Given this list of marker genes SF3B4, WNT7A, PORCN, SEM1, TAF6, RIPK4, BRD4, TP63, CYP26B1, APC, NIPBL, DLX6, HOXD13, H4C3 (H4 clustered histone 3), MBTPS2, SMOC1, DLL4, BTRC, DLX5, FBXW4, SMC3, EPS15L1, SMC1A (structural maintenance of chromosomes 1A), WNT10B (Wnt family member 10B), RAD21, DONSON, HDAC8, LRP4, RECQL4, ERI1, GLI3, here is a description of the gene set: species: Homo sapiens Human Gene Set: HP_OLIGODACTYLY Oligodactyly A developmental defect resulting in the presence of fewer than the normal number of digits.